Given this list of marker genes Syt1, Ppfia3, Vamp2, Tspoap1, Slc22a2, Rab3a, Slc22a1, Stx1a, Cplx1, Ppfia2, here is a description of the gene set: This event has been computationally inferred from an event that has been demonstrated in another species.<p>The inference is based on the homology mapping from PANTHER. Briefly, reactions for which all involved PhysicalEntities (in input, output and catalyst) have a mapped orthologue/paralogue (for complexes at least 75% of components must have a mapping) are inferred to the other species. studied in species Mus musculus Reactome Pathway: Norepinephrine Neurotransmitter Release Cycle part of: Neurotransmitter release cycle electronically inferred by orthology from the curated human pathway